Given this list of marker genes KCNJ11, CDKN1B, RNF43, LMNA, PRKAR1A, GDNF, KRIT1, TRAF7, CDKN2C, PDE11A (phosphodiesterase 11A), SDHB, YY1, MBD4, MDH2, DNMT3A, SPTBN1, SDHAF2, KIF1B (kinesin family member 1B), MYO1H, HRAS, SDHD, EPAS1, DLST, MAX (MYC associated factor X), CDKN2B, PIK3CA, CCND1, APC, MLH1, TSC1, LBX1, RET, GNAS, SPRED1, EDN3, BDNF, MEN1, KDM1A, SLC25A11, TSC2, TERT, AKT1 (AKT serine/threonine kinase 1, NCBI Gene Id 207), ARMC5, PDCD10, SDHA, SMARCE1, COQ6, IFNG, VHL, CCM2, TMEM127, FH, PHOX2B, GCGR, NF1, KARS1, SMO, KIT, CDKN1A, ASCL1, SDHC, MAFA, BAP1, SUFU, NF2, LZTR1, PDGFB, LRP1, ATRX, SMARCB1, here is a description of the gene set: Neoplasm of the peripheral nervous system A benign or malignant neoplasm (tumor) of the peripheral nervous system. studied in species Homo sapiens Human Gene Set: HP_NEOPLASM_OF_THE_PERIPHERAL_NERVOUS_SYSTEM